Given this list of marker genes PDS5B, MCM8, LIN54 (lin-54 DREAM MuvB core complex component), ADRM1, AKT3, PSMD8, POLE2, UBE2D1, AKT1, MCM7, CDC26, CCNE1, PSMC1, PRIM2, PSMB6, POLD3, ORC2, PSMA7, MCM5, CABLES1, PSMB3, POLD4, SMC1A, PSMB1, POLA1, AKT2, MCM4, PSMD13, ANAPC2, CDC27, CDC16, PSMB7, UBE2C, RPS27A, UBE2E1, PSMB5, TFDP2 (NCBI Gene Id 7029), RBBP4, PRIM1, PSMD2, CCNE2, ANAPC10, PSMA6, PSMD11, PSMA5, SEM1, FZR1, PCNA, CDK4 (cyclin dependent kinase 4), E2F1 (NCBI Gene Id 1869), POLD1, UBC, CCNA2, STAG1, ESCO2, PSMC5, ANAPC11, ORC5, GINS3, MNAT1, RPA1, PSMB2, PDS5A, PSMA3, PSMD12, ANAPC7, TFDP1, MAX, E2F4, PSMD3, PSMC3, ANAPC16, E2F5 (E2F transcription factor 5), CCNH, MCM2, RPA3, CDC25A, UBB, DNA2, ANAPC15, ESCO1, WEE1, GINS1, POLE3, LIN52 (NCBI Gene Id 91750), WAPL, PTK6, RAD21, CDK2, POLE4, GINS4, UBE2S, PSMD6, FEN1, CDK7, RFC4, POLE, SKP2, RFC2, PSMC6, LIN9, SKP1, PSMB4, RBL2, RFC5, PSMA2, CDKN1B, CDCA5, POLA2, PSMD1, MYC, CUL1, CCNA1, UBA52, GSK3B, PSMA1, GMNN, STAG2, ORC4, CDC45, SMC3 (structural maintenance of chromosomes 3, NCBI Gene Id 9126), RFC1, ANAPC1, CDC6, RFC3, PSMC4, PSMA4, RBX1, CDC25B, PSMD7 (proteasome 26S subunit, non-ATPase 7), MCM6, PSMC2, RPA2, ORC3, LIN37, CDKN1A, RB1, POLD2, ANAPC5, ORC6, CDC23, CCND1, PSMD14, GINS2, MCM3, CKS1B, ORC1, LIG1, CDT1, ANAPC4, here is a description of the gene set: S Phase species: Homo sapiens Human Gene Set: REACTOME_S_PHASE